The following is a description of a gene set: Marker genes curated from the annotated cluster as represented in the Descartes Human Gene Expression During Development database. Human Gene Set: DESCARTES_FETAL_ADRENAL_ADRENOCORTICAL_CELLS from publication Cao J, O'Day DR, Pliner HA, Kingsley PD, Deng M, Daza RM, Zager MA, Aldinger KA, Blecher-Gonen R, Zhang F, Spielmann M, Palis J, Doherty D, Steemers FJ, Glass IA, Trapnell C, Shendure J (PMID 33184181) species: Homo sapiens The gene expression program underlying the specification of human cell types is of fundamental interest. The study authors generated human cell atlases of gene expression and chromatin accessibility in fetal tissues. For gene expression, the study authors applied three-level combinatorial indexing to >110 samples representing 15 organs, ultimately profiling ~4 million single cells. The study authors leveraged the literature and other atlases to identify and annotate hundreds of cell types and subtypes, both within and across tissues. Our analyses focused on organ-specific specializations of broadly distributed cell types (such as blood, endothelial, and epithelial), sites of fetal erythropoiesis (which notably included the adrenal gland), and integration with mouse developmental atlases (such as conserved specification of blood cells). These data represent a rich resource for the exploration of in vivo human gene expression in diverse tissues and cell types., and this is the list of marker genes: MMADHCP2, ENSG00000229664, C1QTNF1-AS1, ENSG00000229425, RGS8, ECI2-DT, ENSG00000253574, LINC02045, RNU6-56P, ENSG00000260599, MGC27382 (NCBI Gene Id 149047), LINC03086, LINC01717, RNU6-944P, LINC01485